The following is a description of a gene set: studied in species Homo sapiens MAPK1 (ERK2) activation Human Gene Set: REACTOME_MAPK1_ERK2_ACTIVATION, and this is the list of marker genes: JAK1, JAK2, TYK2, PTPN11, MAPK1, MAP2K2, IL6, IL6R, IL6ST